The following is a description of a gene set: part of: Apoptotic factor-mediated response electronically inferred by orthology from the curated human pathway studied in species Mus musculus This event has been computationally inferred from an event that has been demonstrated in another species.<p>The inference is based on the homology mapping from PANTHER. Briefly, reactions for which all involved PhysicalEntities (in input, output and catalyst) have a mapped orthologue/paralogue (for complexes at least 75% of components must have a mapping) are inferred to the other species. Reactome Pathway: Cytochrome c-mediated apoptotic response, and this is the list of marker genes: Casp7, Casp3, Mapk3, Apip, Casp9, Cycs, Aven